The following is a description of a gene set: Human Gene Set: GSE17721_CTRL_VS_GARDIQUIMOD_1H_BMDC_UP studied in species Homo sapiens from publication Amit I, Garber M, Chevrier N, Leite AP, Donner Y, Eisenhaure T, Guttman M, Grenier JK, Li W, Zuk O, Schubert LA, Birditt B, Shay T, Goren A, Zhang X, Smith Z, Deering R, McDonald RC, Cabili M, Bernstein BE, Rinn JL, Meissner A, Root DE, Hacohen N, Regev A (PMID 19729616) mouse primary BMDCs were stimulated with tlr ligands and gene expression changes were profiled on Affymetrix arrays Genes up-regulated in comparison of control dendritic cells (DC) at 1 h versus those stimulated with Gardiquimod (TLR7 agonist) at 1 h., and this is the list of marker genes: FA2H, HVCN1, AQP7, RAB1B, ABCA2, ELOF1, PHF19, GNAI1, LTBR, RASSF9, TAMALIN, KIF21B, KDM3A, GBA1, ARGLU1, BAK1 (BCL2 antagonist/killer 1), SYT17, ADNP, PEF1, SLC39A13, PTPMT1, PLGRKT, PEX11A, DEPDC7, ADRA2B, EMP3, HHEX, GCGR, GCA, ECHDC2 (NCBI Gene Id 55268), MRPL4, GAK, LEPR (NCBI Gene Id 3953), PLEKHF1, RBM5, CUEDC2, RASAL2, PPP1R17, STOML2, ABTB1, HPGD, MYLIP, SLTM, CDC42SE1, ALKBH4, DYRK1A, GJC2, TBX1, BUB1, APOA1, PHACTR1, IRGM, TALDO1, MC3R, MRPL30, ZC3H11A, RAB33B, ATP1A1, ITGB6, SON, KCNN4, TRIM54, GLUD1, PPP2R3A, GNB1, CLIP1, KLHL21, ATP5MC2, PHF23, CCNB2, NAPB, ATG12, DPP7, UXT, P2RX4, SRRM4, NELFE, MPDU1, MST1R, AKR1B1, TC2N, RAB40C, PDLIM2, RUFY3, FGF8, COPS6, STARD3NL, HNF1A, DIP2B, LSM3, HM13, NCMAP, ZNF467, PGD, RRP7A, TMEM147, MYNN, SLC12A9, GPANK1, PCNX1, SPIN1, LYPLA2, GRK2, RYR2, CCDC115, MRM1, OSTF1, MYRF, OCSTAMP, MYF5, ANGPT1 (angiopoietin 1), GIGYF1, PCYOX1, ADH5, CEP250 (NCBI Gene Id 11190), CAMK2G, B3GNT5, KEL, AKT1, CHM, TMEM229B, COL8A1, NAA60, ZFYVE19, LENG8, DMKN, MED22, KRTAP21-1, STAT2, RNF34, ANAPC5, DOLPP1, B3GNT3, LTBP4, MIDN (midnolin), CD1D, MSI1, PTPRG, D2HGDH, GDPD3 (NCBI Gene Id 79153), SKA1, PCBP2, INSM1, DGAT1, GRM1, TPSG1, ZSCAN5B, RPS6KA4, OXLD1, YBX2, MSANTD2, SARS1, EIF3H, PRRX2, ARPC4, PTPRJ, TLN1, FLCN, HMX3, FHIP2A, SENP3 (NCBI Gene Id 26168), HNRNPLL, CENPB, EVA1A, LIMK2, BNIP2, FAM32A, AACS, EPHB2, COMMD2, STARD3, ZNF841 (NCBI Gene Id 284371), C6orf58, BCL11B (BCL11 transcription factor B), PTGIR, AKNA, ARRB1, NHERF4, DOK3, AHDC1, TNRC6A, HEBP2, PSMD5, MSL2, PIGS, CPNE2, CPSF4, OTULIN, N4BP3, GALR3, ESRP2, GLMN, MOCS2, TUSC2, ACRBP, SERTAD1, RPL6, TRIM25, TBC1D13, SUPT20H